Given this list of marker genes Lilrb4b, Hmgb1 (high mobility group box 1), Pou4f1, Irf1, Slc4a2 (solute carrier family 4 (anion exchanger), member 2), Mafb, Fam210b (family with sequence similarity 210, member B, NCBI Gene Id 99270), Sh3rf1, Tmem176a, Abcb10 (NCBI Gene Id 97438), Lox, Gimap5, Smarce1, Il34, Hsf1, Pithd1, Card11, Arid2, Ccr6, Lyn, Ikzf3, Prdm1, Eeig1, Gimap3, Brd7, Pik3r6, Myc, Notch2, Paf1, Ccr7, Dcstamp, Casp8 (NCBI Gene Id 12370), Twist2, Kat2a, Cd1d1, Zfp608, Mef2c, H2-M3, Fshr, Hspa9, Prdm16 (NCBI Gene Id 70673), Fgfr3, Ctr9, Kitl, Ihh, Tob2, Zbtb7a, Senp1, Foxn1, Hoxb8, Cartpt, Csf3r (NCBI Gene Id 12986), Fshb, Adrm1, Myb, Gas6, Ap3b1, Smarcd2, Smarca4, Ppargc1b, Fgl2, Fbn1, Gpr137, Ocstamp, Csf1, Mapk14, Egr3, Faxdc2, Pcid2, Gata1, Ubash3b, Mmp14, Arid1a, Ptk2b, Meis2, Tmem176b, Zfpm1, Cebpa, Ypel4, Inpp4b, Tgfb1, Adipoq, Bcl6, Socs5, Mettl3, Prelid1, Setd1a, Ccl9, Mir150, Thoc5, Rag1, Zeb1, Zmiz1, Cd69, Smarcd3, Actb, Btn2a2, Acvr2a, Acvr1b, Clptm1, Il21, Ripk2, Clec12a, Irgm1 (NCBI Gene Id 15944), Abl1, Hsp90aa1, Asxl2, Il2rg, Il7, Prkcz, Ccl20, Cd40lg, Ifnb1, Il4ra, Cldn18, Brd4, Rc3h1, Il5, Ascl2, Zfp683, Prxl2a, Sh2b3, Dtx1, Cd46, Pla2g3, Fancd2, Xrcc6, Actl6a, Il20, Nkap, Ripk1, Lilrb4a (leukocyte immunoglobulin-like receptor, subfamily B, member 4A), Drosha, Zc3h12a, Mturn, Zbtb46, Fbxo7, Ceacam1, Cd44, Meis1, Ctla4, Tnfrsf11a, Dicer1, Rab7b (NCBI Gene Id 319567), Meaf6, Ctnnbip1, Hif1a, H2-Aa, Il1rl2, Cyp26b1, Smarcc2, Fes, Cyld, Cdk6, Dusp10, Tnfaip6, Ankrd54, Nlrp3, Rasgrp1, Gnas, Ccl21b, Evi2, Cul4a, Tesc, Gpr68, Prkca, Ccr1, Fos, Zfp609, Med1, Skint1, Pilrb1, Rhoa, Ets1, Nfkbia, Bmp4, Tcf7, Fbxw7, Kat6a, Cd27, Klf10, Eif6, Gfi1b, Tnf, Pias3, Ing5, Il4, Zc3h8, Cd101 (CD101 antigen), Nme2, Sart1, Foxj1, Slc9b2, Smap1, Mir125a, Smad7, Ambra1, Phf10, Anxa1, Zfp36, Mysm1, Ninj1, Rbfox2, Glul, C1qc, Tlr9, Il27, Ctla2a, Nfam1, Il7r, Il15, Hoxa9, Skic8, Il15ra, Lef1, Cib1, Crtam, Sox4, Tmem178, Il10, Rag2, Atg7, Slamf8, Smarcb1, Smarcd1, Csf1r, Mir223, Sos1, Ankle1, Jun, Ror2, Il12b, Pira1, Malt1, P4htm (NCBI Gene Id 74443), Kat6b, Vnn1, Tmem64, Bmyc, Ppp3ca, Runx3, Carmil2, Ap3d1, Sox13 (SRY (sex determining region Y)-box 13), Ikzf1, Tnfsf11, Inpp5d, Fstl3, Socs1, Braf, Sash3, Kat5, Atp11c, Flt3, Klf13, Cd28, Flt3l, Rnf41, Prkdc, Fas, Kat7, Cd74, Kdm1a, Prmt1, Dlk1, Cd4, Shb, Tox, Il36b, Clec2i, Brpf3, Stat1, Tal1, Tcta, Itpkb, Il6, Lmo2, Gata3, Axl (AXL receptor tyrosine kinase), Mir326, Leo1, Rptor, Inhba (inhibin beta-A), Syk, Pbrm1, Rarg, Smarcc1, Gpr137b, Actl6b, Nrarp, Zfp36l1, Hoxa5, Nckap1l, Foxp3, Nedd9, Bad, Cebpb, Evi2b, Il23a, Gpr171, Loxl3, Lif, Nfkbid, Gsk3b, Stat3, Il12a, Rbm15, Cd83, Esrra, Jak3, Rassf2, Gpr55 (NCBI Gene Id 631726), Pik3r1, Jag1, Tcim, Siglec15, Adam8, Nme1, Trem2, Gli3, Zbtb1, Rara, Hmgb2, Ccr1l1, Ptprc, Iapp, Snai2, Zbtb7b (NCBI Gene Id 22724), Slc46a2, Car2, Runx1, Pglyrp2, Lag3, Tjp2, Lck, Acin1, Il18, Lgals9 (NCBI Gene Id 16859), Id2, Clec4g, Thpo, H2-Ea, Fanca, Xbp1, Hax1, B2m, Scin, Ccl5, Nf1, Zfp36l2, Ager, Apcs, Ldb1, Pglyrp4, Brd2, L3mbtl1, Ccr2, Sos2 (NCBI Gene Id 20663), Mdk, Tmem131l, Wnt10b, Cdkn2a, Ctnnb1, Tescl, Mir301, Rcor1, Cd24a, Shh, Pnp, Hoxa7, Mpl, Foxo3, Clec2d, Zfp35, Hlx, Pglyrp1, Pf4, Dll1, Hspa1b, Ccl19, Apc, Itgam, Rorc, Ccl3, Il3, Il4i1, Cnot4, Mitf, Sox12 (SRY (sex determining region Y)-box 12), Duxbl1, Erbb2, Ifng, Erfe, H2-DMa (NCBI Gene Id 14998), Kcnk18, Rhoh, Tgfbr2, Cdc73, Fadd, Ltf, Rbp1 (retinol binding protein 1, cellular, NCBI Gene Id 19659), Foxp1, Il17a, Itgb3, Pou4f2, Vsir, Nfkbiz (NCBI Gene Id 80859), Tnfsf4, Lgals1, Ptpn2, Tyrobp (NCBI Gene Id 22177), Hcls1, Qki (NCBI Gene Id 66145), Tnfsf18, Hmgb3 (NCBI Gene Id 15355), Clec2g, Ada, Lrrc17, Rc3h2, Prdx2, Tnfrsf11b, Isg15, H2-Oa, Pglyrp3, Il2ra, Zap70, Opa1, Ndfip1, Mtor, Ddrgk1, Csf3, Sfrp1, Creb1, Brd1, Pck1, Klhl25, Gabpa, Tfe3, Smarca2, Ep300, Traf6, Tespa1, Stat5a, Tbx21, Pira12, Il17d, Spi1, Tsc22d1, Il2, Ptpn6, Rb1, Gata2, Cbfb, Tnfsf9, Stat5b, Ppp2r3c, Hspb1, Trib1, Ptn, here is a description of the gene set: Any process that modulates the frequency, rate or extent of hemopoiesis. species: Mus musculus Mouse Gene Set: GOBP_REGULATION_OF_HEMOPOIESIS